Given this list of marker genes HMMR, TK1, AGT, ISYNA1, CDC20, AURKB, UBE2C, KPNA2 (NCBI Gene Id 728860), TRAPPC5, KIFC1, KIF22, CCNB1, EXOSC5, AQP1, TOP2A, BBLN, WFDC12, NUSAP1, SRSF1, ANLN, BUB1, GALK1, RACGAP1, H2AX, KIF20A, PTTG1, SLPI, ELAVL1, ANXA8L1, RRM1, RANGAP1, CAD, LCN2, STMN1, S100A8, CDK1, DCTPP1, CENPL, SNRNP70, MELK, IPO5, CCNA2, PRC1, CDC25C, here is a description of the gene set: The molecular mechanisms that regulate cellular differentiation during development and throughout life are complex. It is now recognized that precise patterns of differentially expressed genes ultimately direct a particular cell toward a given lineage and many of these are regulated during the earliest stages of differentiation. Using a microarray-based expression analysis, we have examined gene expression profiles during the first 24 h of 3T3-L1 adipocyte differentiation. RNA was isolated at times 0, 2, 8, 16, and 24 h following stimulation of differentiation and hybridized in duplicate to high density Affymetrix microarray gene chips containing a series of 13,179 cDNA/expressed sequence tag (EST) probe sets. Two hundred and eighty-five cDNA/ESTs were shown to have at least a fivefold change in expression levels during this time course and both hierarchical and self-organizing map clustering analysis was performed to categorize them by expression profiles. Several genes known to be regulated during this time period were confirmed and Western blot analysis of the proteins encoded by some of the identified genes revealed expression profiles similar to their mRNA counterparts. As expected, many of the genes identified have not been examined in such a critical time period during adipogenesis and may well represent novel adipogenic mediators. species: Mus musculus Human Gene Set: BURTON_ADIPOGENESIS_PEAK_AT_24HR Cluster 5: genes progressively up-regulated (peak at 24 h time point) during differentiation of 3T3-L1 fibroblasts into adipocytes in response to adipogenic hormones. from publication Burton GR, Guan Y, Nagarajan R, McGehee RE Jr (PMID 12137940)